Given this list of marker genes Wnt3a, Pax6, Rhoa, Wnt7b, Sema3g, Ascl2, Trpc5, Dusp10, Trp53, Elapor2, Nrp1, Epha7, Pitx3, Pten, Ptprs, Id4, Cbln1, Bmp4, Gsk3b, Gpr37l1, Dlx1, Cers2, Plxna3, Hook3, Rufy3, Kdm4a (NCBI Gene Id 52239), D130043K22Rik, Gata2, Il1b, Fgf13, Trak2, Dicer1, Prox1, Ctdsp1, Tspo, Id1, Lingo1, Trim11, Ctnnb1, Sema3f, Clstn3, Atf5, Prtg, Cdkn2b, Ptpn13, Lrp4, Draxin, Ttc3, Robo1, Actr3, Ryk, Idh2, Mbd1, Tgfb1, Sema4f, Kdm1a, Hmga2, Dkk1, Trem2, Tnr, Dpysl5, Lhx2, Cd24a, Efnb3, Gdi1, Map2, Slit1, Trim46, Dab1, Cysltr2, Kctd11, Mt3, Ptn, Wnt7a, Slit2, Lin28a, Ccr5, Rnf10, Wnt3, Dnajb11, Ifrd1, Dynlt1b, Fgfr3, Nfatc4, B2m, Sema3a, Cdk5, Vax1, Psen1, Atoh1, Kifap3, Nf1, Sirt2, Dll3, Sema6c, Ntrk3, Daam2, Thy1, Gorasp1, Ntn1, Rb1, Sema6d, Rtn4, Mecp2, Rapgef2, Nf2 (neurofibromin 2), Rtn4r, Mag, Id2 (NCBI Gene Id 97802), Trpc6 (transient receptor potential cation channel, subfamily C, member 6), Brinp1, Nkx6-2, Ywhah, Hes1, Dip2b, Rest, Ptk2 (PTK2 protein tyrosine kinase 2), Cit, Mdga1, Ulk1, Sox10, Tsc2, Appl2, Nr1d1, Ski, F2, Cdh1, Tlr2, Ldlr, Bmp7, Ctnna1, Rnf6 (ring finger protein (C3H2C3 type) 6), Adcyap1, Syngap1, Mfn2, App, Vsx2, Tert, Bdnf, Syt4, Fas, Tmem98, Arhgap4, Bcl11a, Spart, Arhgef2 (Rho/Rac guanine nucleotide exchange factor 2), Sorl1, Nkx6-1, Drd3, Ephb2, Cdkl3 (NCBI Gene Id 213084), Hdac6, Ulk2, Tlx2, Pcm1, Mbp, Btg2, Fstl4, Sema5a, Bmpr1a, Casz1, Dlx2, Nog, Mycn, Notch1, Sox11, Abcc8, Hes5, Nr2e1, Ccl11, Wnt5a (wingless-type MMTV integration site family, member 5A), Rgma, Ppp3ca, here is a description of the gene set: Any process that stops, prevents, or reduces the frequency, rate or extent of nervous system development, the origin and formation of nervous tissue. Mouse Gene Set: GOBP_NEGATIVE_REGULATION_OF_NERVOUS_SYSTEM_DEVELOPMENT species: Mus musculus